The following is a description of a gene set: Dendritic cells (DCs) are potent mediators of the immune response, and can be activated by exogenous pathogen components. Galectin-1 is a member of the conserved beta-galactoside-binding lectin family that binds galactoside residues on cell surface glycoconjugates. Galectin-1 is known to play a role in immune regulation via action on multiple immune cells. However, its effects on human DCs are unknown. In this study, we show that galectin-1 induces a phenotypic and functional maturation in human monocyte-derived DCs (MDDCs) similar to but distinct from the activity of the exogenous pathogen stimuli, LPS. Immature human MDDCs exposed to galectin-1 up-regulated cell surface markers characteristic of DC maturation (CD40, CD83, CD86, and HLA-DR), secreted high levels of IL-6 and TNF-alpha, stimulated T cell proliferation, and showed reduced endocytic capacity, similar to LPS-matured MDDCs. However, unlike LPS-matured DCs, galectin-1-treated MDDCs did not produce the Th1-polarizing cytokine IL-12. Microarray analysis revealed that in addition to modulating many of the same DC maturation genes as LPS, galectin-1 also uniquely up-regulated a significant subset of genes related to cell migration through the extracellular matrix (ECM). Indeed, compared with LPS, galectin-1-treated human MDDCs exhibited significantly better chemotactic migration through Matrigel, an in vitro ECM model. Our findings show that galectin-1 is a novel endogenous activator of human MDDCs that up-regulates a significant subset of genes distinct from those regulated by a model exogenous stimulus (LPS). One unique effect of galectin-1 is to increase DC migration through the ECM, suggesting that galectin-1 may be an important component in initiating an immune response. species: Homo sapiens Human Gene Set: FULCHER_INFLAMMATORY_RESPONSE_LECTIN_VS_LPS_UP Genes up-regulated in monocyte-derived dendritic cells (MDDC) after stimulation with galecin-1 (lectin, LGALS1) compared to that with bacterial lipopolysaccharide (LPS). from publication Fulcher JA, Hashimi ST, Levroney EL, Pang M, Gurney KB, Baum LG, Lee B (PMID 16785517), and this is the list of marker genes: TSC22D1, AUH, COX18, RGS1, METTL9, POLE4, PPA2, CD55, ALOX15B, GGH, IRF4, EPOP, ACSL3, TMEM255A, SLX4 (NCBI Gene Id 84464), CD82, FOXN3 (NCBI Gene Id 654111), TGFA, CLEC7A, RPL10A, MMP1, MRPS24, SPINT1, SLC22A4, PEA15, FASTKD1, GON7, MRPL52, PTGS1, NUDT4, TMEM208, JTB, TMEM14C, SSR2, ARPC5L, TBC1D13, PDGFC, SMIM20, G6PD, PHACTR2, CXCL3, RHOC, TIAM1, TPMT, MARCHF8, FCRLB, CLN8-AS1, C1orf54, VASP, DENND1B, WFDC21P, TOMM34, NAAA, ANAPC16, BHLHE41, SLC30A5, PEF1, TM2D1 (NCBI Gene Id 83941), ACTN1, ZNRD2, SLC7A1, DIPK1A, GP1BA, C3, MTMR14, SIGLEC5, DTX4, SH3BGRL3, TNC, ZNF697, EML4, EYA3, BCAT1 (NCBI Gene Id 586), CYBB, RAB31, PLAT, TNFSF13, TBL1XR1, SRXN1, DPH3, KIF5B, CLC, NDUFAF8, CST7 (NCBI Gene Id 8530), AKIRIN1, GLYR1, KIAA1671, PAN2, F3, SLC3A2, LINC01857, EEF1E1, CRIM1, PDLIM4, GLS, TAGLN2, NDUFA2, IGSF6, MOB3B, TBC1D4, TMEM273, PLAU, RAP2A, SMIM19, LAMP3, ST3GAL2, ADTRP, SDC2, GRPEL1, SLAMF8, CRLF2, DCTPP1, SOCS2, DHRS11, PGM2, SLC7A8, NDUFV3, MPEG1, STK4, NME1, SMAD6, TRABD, CD226, NR4A3, CDYL, MSANTD3, SPP1, FBXL4, GAL, JPT1 (Jupiter microtubule associated homolog 1), MPZL1, SIGLEC15, CFP, TUBB2A, MMP19, HOPX, MAD2L2, TXNRD1, TTC9C, POLR2F, PDLIM7, SNX8 (NCBI Gene Id 29886), CCL22, MCCC2, IL27RA, DAD1, FSD1L, RHOF, NENF, GSR, MPC2, NRIP3, BZW2, KIF2A, PRXL2B, MRPS16, DUSP22, REL, AKR1C3, CXCL1, CALM1, ST7, VAC14, MKKS, CCDC71L, CD276, SUB1, ETHE1, IARS1, ZNF366, IL1A, RGCC, NHP2, TRAP1 (NCBI Gene Id 51721), CCL17, NAP1L1, PTRHD1, STAC, ITPR1, PTPRO (protein tyrosine phosphatase receptor type O), CCNG2, PHTF2, EEIG2, SPI1, SMAD7, SERINC2, CARD9, NEK6, AK8, NSMCE1, RPS19BP1, UBE2G2, PRPF8, YRDC, IL1RAP, ZDHHC12, SOAT1, IL1B, LPL, FADD, YPEL5, MYO18A, SPIN4, TNFRSF9, HIPK2, COMMD1, GFOD1, POLR3K, NDUFS8, CMC4, MAPK13, NELFE, PRKCA, SPRED2, LPP, LTV1, TRAF3IP3, PROCR, FCER2, PTS, SUMF1, UBE2W, FXYD6, TFPI, TCF3, SEMA7A, DCUN1D1, COA3, BATF3, COMMD7 (NCBI Gene Id 85361), TMED3, DUSP6, ATP1B1, HOMER2, ENTPD4, AQP3, GALNT12, MEI1, MMP12, MYO5A, MET, GPR157, SHPK, MFNG, CSRP1, NET1, SOWAHC, ABCC3, THBD, CEP20, LSP1 (lymphocyte specific protein 1), MAP3K13, RHBDD2, VCL, GPR107, H2AX, MARCKSL1 (MARCKS like 1), MTHFD2, SH3KBP1, ADAM8, YIF1A, CLEC4A, GLRX3P2, TMEM132A, STYXL1, TREM1, MMP10, COQ9, GPAT3, ABL2, MCOLN3, PIK3CG, LMAN1, FN1, SCARF1, HCAR3 (hydroxycarboxylic acid receptor 3), TIMM10B, JUN, MGST1, FSCN1, NFAT5 (nuclear factor of activated T cells 5), IL1RN, LPAR1, GSN, POLD4, MYO1E, NIBAN1, SH3BP5, SLC7A11, STMP1, NMD3, IL7R, MT1E, SND1, DUSP4, SUN2, ALG2, HIP1, COL6A1, ADAM12, RCN2, SOX4, AKR1C1, COLEC12, RRS1 (NCBI Gene Id 90810), MRTO4, H6PD, NEDD4L, RAB27A, TMEM14B, CASP2, SLC44A1, EEF2K, FAM162A, UBXN1, CIAPIN1, TIFAB, EDEM1, WDFY4, LONRF1, MYH9, MFSD14CP, ISOC1 (NCBI Gene Id 51015), ACSL5, MSC-AS1, AGTRAP, POLR1D, MARCHF3, NDUFV2, TRAF1, CARD19, SYT17, TRAPPC2L, ST3GAL5, FCAR, NISCH, PNPLA6, GTF3A, ARHGAP22, HINT1, IL6, HPS3, MICAL2, FCGR2A, CNPY2, MAP3K5, RTN1, NQO1 (NCBI Gene Id 4834), CLEC4G, TBC1D22A, RAB11FIP1, LYRM1, MAP3K20, HMOX2, BCAR3, PPP3CA, EDEM2, CSF1, SLC39A9, PLK3, SGTA, PSTPIP1, ITGB3, ABCC1, HIKESHI, WDR12, TCF4, CAVIN1, TNFRSF6B, SERPINB2, MT1X, HLA-DRB1, CMTM3, TNIK, TGFBR1, ST3GAL6, SLC25A40, SULF2, SLC30A4-AS1, ASPH, TUBB6, NUS1, GOT2, SRC, LRRC32, NFKBIE, MT1H, CXCL2, OIP5-AS1, SMDT1, PLAUR (NCBI Gene Id 5329), RHOQ, TNFRSF11A, CCL26 (NCBI Gene Id 155403), ACO1, RCAN1, ALCAM, EHF, ABHD2, PEX19, NME7, FCGR2B, G3BP1 (G3BP stress granule assembly factor 1), BTG2, GLIPR1, LAT2, CPED1, RASGRP1, ZYX, HSPA6, ETS2, B3GNT5, VAPA, EFCAB14, TNFRSF4, ECM1, RUNX1, CERS6, MPHOSPH6, PDPN, SGPP2, GPR68, DCLRE1B (NCBI Gene Id 64858), GALNT6, TRGC1, DCSTAMP, FCGR1A, CMC2, CBR3, TGM2, POLR2G, IVNS1ABP, P2RY6, LRRC8C, PKIB (cAMP-dependent protein kinase inhibitor beta), OLR1, HMG20B, AK4, EDN1, GGT5, ACER3, GATD3, RAI14, FAR2, ERO1A, TENT4B, SNHG16, CXCL5, TRIAP1, P4HA2, MFSD12, ALOX15, CCNA1, ACOT7, EVI2A, AHCYL1, LAT, SIGLEC7, LGALS2, SLC39A11, AKR7A2, CTNNAL1, ZMIZ1-AS1, LRP8, PACC1, NRP1, CHST2, SDCCAG8, ANP32A, MINPP1, PPARD, MIR3945HG, TAPT1, EREG, IRF2BP2, FABP3, GADD45G, MT1F, PTGR1, MFSD2A, CALD1, NOPCHAP1, CLN8, UXS1, DCUN1D3, GPR35, POGLUT1, CCL24, CXCL8 (C-X-C motif chemokine ligand 8), PMP22 (NCBI Gene Id 5376), CYB5B, UBR4, SESN3, GLTP, ATP2A3, CD209, HAX1, SLC20A1, MAP2K6, HNRNPLL, PHLDA2, LYPD3, RABEPK, SLC41A2, RHOH, SNHG5, MOB3A, MICALL1, PPP1R14A, HBEGF, SIGLEC10, JAGN1, TMX2, MRPL51, ARHGAP10, BIRC3, EMG1, DNASE1L3, FAM120A, KCNN4, PMAIP1, SRPRB (NCBI Gene Id 58477), MB21D2, TNFSF9, NETO2, CYTOR, P2RX4, CSK, CCL15, CSF2RA, NDFIP2, CKLF, CCNI, ORAI1, CMIP, PLEKHA5, RFLNB, SMOX, WNT5A, FKBP5, PNP, SDF2, INHBA, LIMK1, SLC25A11, MAFF, RAC2, CCL13, KCNK6, GPR160, RANBP1, PIR, SINHCAF, FMNL2, TNFAIP8L2, ATP2C1, STEAP3, CD109, CNIH3, ASAP1, IL2RG, MAPKAPK3, TNFSF8, TIMM10, MRPS12, PTDSS1, SLC6A6, MCEMP1, FNDC3A, ETV3, NCS1, PRKD3, TEX261, SLC27A3, SELENOW, CBX6, CD40, BID, MYOF, BOLA3, NDRG1, KHSRP, B3GALNT1, CD93, ADAM19